The following is a description of a gene set: The conversion of N-linked glycan (N = nitrogen) structures from the initially transferred oligosaccharide to a mature form, by the actions of glycosidases and glycosyltransferases. The early processing steps are conserved and play roles in glycoprotein folding and trafficking. studied in species Mus musculus Mouse Gene Set: GOBP_N_GLYCAN_PROCESSING, and this is the list of marker genes: St8sia2, Fut8, Prkcsh, Ganc, St8sia4, St8sia3, Mgat4a, Gnptab, Hexa, Man2a2, St8sia1, Ganab, St8sia5, Engase, St8sia6, Man2a1, Hexb